The following is a description of a gene set: studied in species Mus musculus The process that results in the generation of glial cells. This includes the production of glial progenitors and their differentiation into mature glia. Mouse Gene Set: GOBP_GLIOGENESIS, and this is the list of marker genes: Phgdh, Tspan2, Gap43, Zmiz1, Pick1, Psen1, Tlr2, Sox6, Dab2ip, Sod1, Gpm6b, Suz12, Rras, Ntrk2, Dll3, Dhh, Plp1, Tmem98, Prmt5, Cers2, Ndn, Prkch, Cntn1, Lamb1, Atxn1 (ataxin 1), Vax1, Ccl3, Ptpra, Trp53, B4galt5, Casz1, Tnfrsf1b, Prdm8, Tgfb2, Omg, Dusp15, Myd88, Bnip3, Mfn2, Cntnap1 (NCBI Gene Id 53321), Rb1, Il6st, Hdac1, Dlx1 (NCBI Gene Id 13390), Nfia, Abca2, Nrg1, Mag, P2rx4, Fn1, Pitx3, Disc1, Gsx2, Nab1, Dll1, Sox13, Sh3tc2, Epha4, Shank3 (SH3 and multiple ankyrin repeat domains 3, NCBI Gene Id 58234), Il33, Serpine2, Nog, Ptn, App, Sox10, Lgi4, Gpr37l1, Pmp22, Map2k2 (NCBI Gene Id 26396), Ptprj, Mal, Tppp, Creb1, Stat3, Pfkfb3, Itgb4, Trem2, Tspo, Kras, Pdgfb (NCBI Gene Id 18591), Adgrg1, Nfix, Rhoa, Ptprb, Nfib (NCBI Gene Id 77183), Eif2b3, Cdkn2c, Ptprz1 (NCBI Gene Id 433999), Mmp14, Hdac2, P2ry1, Zfp365, Idh2, Adgrg6, Vps13a, Ilk, Ncmap, Csf1, Ldlr (low density lipoprotein receptor), Olig1, C1qa, Mecp2, Clu, Penk, Mxra8, Cntnap2, Qki, Epm2a, Bmp4, Agt, Abcc1, Fgfr3, Eed, Hras, Socs7, Abl1, Wdr47, Pou3f1, Aspa, Gli3, Dicer1, Lta (lymphotoxin A), E2f1 (E2F transcription factor 1), Rnf10, Rtn4, Mobp, Tlr4, Cdh2, S100a9 (NCBI Gene Id 99917), Ascl1, Il34, Clcf1, Arsg, Ror1, Opalin, Mir219a-1, Il6, Wasf3, Zcchc24, Plpp3, Slc7a5, Ezh2, Zeb2, Pax2, Mmp24, Dlg5, Akt2, Trp73, Ano1, Lepr, Sox1, Cx3cr1, Nab2, Cdk5, Tenm4, Ror2, Phox2b, Drd3, Sos1, Fkrp, Sox8, Prpf19, Nf2, Efemp1, Kcnj10, Shh, Nr1d1, Ppp1cc, Lamb2, Gpc1, Med12, Eif2b5, Hes5, Syne2, Adam22, Myc, Ptpn11, Gcm1, Lingo1, Tcf7l2, Mir23a, Dcx, Grn, Cnp, Stap1, Slc25a46 (NCBI Gene Id 67453), 9630013A20Rik, Id4, C5ar1, Mir219a-2, Synj1, Akt1, Igf1, Dbi, Grin1, Vcan, Cysltr1, Eif2b4, Ntf3, Ulk4 (unc-51-like kinase 4), Vtn, Raf1, Slc8a3, Vegfc, Lrp1, Lyn, Nrros, Prkci, Id2, Arrb2, Ptk2b, Map2k1, Cntn2, Bag1, Dlx2, Nlgn3, Zfp488, Hexb, Eomes, Cdk5r1, Dmd, Mettl14, Sun1, Nsun5, Plec, Rras2, Lamc3, Foxg1, Tuba1a, Sox4, Dusp10, Dab1, Hmga2, Slc45a3, Myb, Adora2a, Tnfrsf21, Gpr17, Cdkn2b, Bmp2, Egr2, Gcm2, Pparg, Abcc8, Gba1, Eif2b2, Hdac11, Naglu, Cspg4, P2ry12, Hes1, Ndufs2, Scrib, Pafah1b1, Sox11, Rnf112, Lama2, Afdn, Tiam1, Reln, Ccl2, Erbb3, Nkx2-2, Enpp2, Large1, Olig2, Mios, Drd1, Mboat7, Gm5849, Sun2, Cd9, B4galt6, Gfap, Mettl3, Lrp8 (low density lipoprotein receptor-related protein 8, apolipoprotein e receptor), Otx2, Cxcr4, Atf5, Lef1, Clcn2, Pou3f2, Bmerb1, Adcyap1, Matn2, Cysltr2, Mbd1, Mapk3, Fubp1, Lpar1, Ncstn, Trpc4, Gjc2, Crb1, Ifngr1, Mdk, Pard3, Exoc4, Csf1r, Cdk6, Trf, Nfe2l1, Lif, Emx1, Itgam, Ski, Nkx2-2os (NK2 homeobox 2, opposite strand), Lrp6, Cspg5, Nkx2-1, Anxa7, Erbb2, Gpr157, Atp1b2, Sox5, Ifng, Ptk2, Vim, Dner (NCBI Gene Id 227325), Wdr1, Fgf10, Arhgef7, Nr3c1, Ccdc85c, Egfr, Prx, Rela, Sox9, Col6a1, Ctnnb1, Fas, Mycn, Cx3cl1, Ndp, Gpr183, Gstp1, Nr2e1, Lin28a, Pi4ka, Myrf, Sirt2, Pten, Nkx6-1, Tert, Pax6, Tnf, Cdk5r2, Dtx1, Bok, Tal1, Ntrk3, Myoc, Mtor, Etv5, Notch1, Fgf5, Csk, Flt1, Ccl12, Kdm4a, Grk2, Actr3, Spint1, Eif2b1, Cntf, Ager, Enpp1, Col3a1, Arhgef10 (Rho guanine nucleotide exchange factor 10), Mfsd8, Ccr2, Pals1, Apcdd1, Grb2, Ufl1, Ntn1, Daam2, Miat, Nf1, Areg, Fa2h, Mapk1, Ccdc39, Abl2, Plag1, Klf15, Ppp3r1, Il1b, Tgfb1, Crkl, Orc3, F2, Ndrg1, Fgf2, Atoh1, Dag1, Ercc2, Vps54, Metrn, Smo, Ascl2, Ttc21b, Nkx6-2, Smarca4, Bin1, Rheb, Cul4b, Srgap2, Neurod4, Lrp2, S100a8, Ckap5